The following is a description of a gene set: from publication Tabula Muris Consortium (PMID 32669714) Mouse Gene Set: TABULA_MURIS_SENIS_PANCREAS_PANCREATIC_STELLATE_CELL_AGEING species: Mus musculus, and this is the list of marker genes: Tle5 (NCBI Gene Id 14797), Pltp, Ptms, Cygb, Rps4x (NCBI Gene Id 20102), Gnb1 (guanine nucleotide binding protein (G protein), beta 1), Ptma